The following is a description of a gene set: studied in species Homo sapiens Neighborhood of BCL2L1 Human Gene Set: GCM_BCL2L1 Neighborhood of BCL2L1 BCL2-like 1 in the GCM expression compendium, and this is the list of marker genes: NF2, BCL2L1, GSPT1, PHF2, CHTOP, WNK1, TRIM33, AAAS, CSRNP2, NUCKS1, COMMD9, BRPF3, FOXO3, TMEM120A, SELENOI, GTPBP1, KDM3B, ISCA1, MEPCE, ASB3, DFFA (DNA fragmentation factor subunit alpha), BOD1L1, ZNF529 (NCBI Gene Id 92279), PAFAH1B2, PRRC2B, CS, UBE2E3, RTN4 (NCBI Gene Id 57142), BAZ2A (bromodomain adjacent to zinc finger domain 2A), PRKRA, TNPO2, RABGEF1, RNF41, RAN, TAF9B